Given this list of marker genes Myoc, Myh9, Cd59a, Tspan5, Atf5, Pitpnb, here is a description of the gene set: studied in species Mus musculus Patterns of gene expression in the central nervous system are highly variable and heritable. This genetic variation among normal individuals leads to considerable structural, functional and behavioral differences. We devised a general approach to dissect genetic networks systematically across biological scale, from base pairs to behavior, using a reference population of recombinant inbred strains. We profiled gene expression using Affymetrix oligonucleotide arrays in the BXD recombinant inbred strains, for which we have extensive SNP and haplotype data. We integrated a complementary database comprising 25 years of legacy phenotypic data on these strains. Covariance among gene expression and pharmacological and behavioral traits is often highly significant, corroborates known functional relations and is often generated by common quantitative trait loci. We found that a small number of major-effect quantitative trait loci jointly modulated large sets of transcripts and classical neural phenotypes in patterns specific to each tissue. We developed new analytic and graph theoretical approaches to study shared genetic modulation of networks of traits using gene sets involved in neural synapse function as an example. We built these tools into an open web resource called WebQTL that can be used to test a broad array of hypotheses. Mouse Gene Set: CHESLER_BRAIN_QTL_TRANS from publication Chesler EJ, Lu L, Shou S, Qu Y, Gu J, Wang J, Hsu HC, Mountz JD, Baldwin NE, Langston MA, Threadgill DW, Manly KF, Williams RW (PMID 15711545) Best trans-regulated quantitative trait loci (QTLs) in the mouse genome which modulate transcription in brain tissue.